The following is a description of a gene set: Human Gene Set: HP_NAIL_DYSTROPHY Onychodystrophy (nail dystrophy) refers to nail changes apart from changes of the color (nail dyschromia) and involves partial or complete disruption of the various keratinous layers of the nail plate. species: Homo sapiens Nail dystrophy, and this is the list of marker genes: RPA1, NHP2, RETREG1, DSP, TERT, KRT17, ATR, ATP2A2, GSN (gelsolin), GJB6, KRT6B, TYMS, BRAF, KIF15, TTC7A (tetratricopeptide repeat domain 7A), CD151, LSS, MPLKIP, WRAP53, PERP, KRT16, ATP6V1B2, LAMB3, COL14A1, KDF1, TNFRSF1B, FOXN1, ACD, MAP2K1, AARS1, IKBKG, LAMA3, PKP1, CTC1, GJA1, DKC1, MBTPS2, ZMPSTE24, KRT6A, PLEC, NLRP1, COX7B, GTF2H5, POLD3, DST, FGFR2, EVC2, PORCN (NCBI Gene Id 65017), LORICRIN, CARS1, KIF1A, AP1S3, ZBTB20, TARS1, PI4KA, EVC, CD28, HPGD, CTSC, HOXC13, ITGA6, NOP10, HLA-B, WNK1, KRAS (KRAS proto-oncogene, GTPase), TP53, RBCK1, FLNA, NECTIN1, AAGAB, KMT2D, ITGB4, SREBF1, MARS1, POMP, SMARCAD1, COL17A1, TERC, KRT85, PQBP1, JUP, NTRK1, ITGA3, NPM1, ERCC3, DCLRE1B, UBE2A, TP63, SCN9A (sodium voltage-gated channel alpha subunit 9), FOXP3, NOTCH1, CTLA4, RSPO1, IL36RN, KLHL24, TGM1, DNA2, KRT1, WNT10A, SMARCE1, SASH1, STING1, RTEL1, RUNX2, MAP2K2, STAT3, MTX2, WRN, GTF2E2, AIRE, MVK, NFKB2, TINF2, MMP1, GJB2, GRHL2, LMNA, NFKBIA, ATL1, PARN, KRT74 (NCBI Gene Id 121391), ANAPC1, FOCAD, CDSN, LAMC2, KRT86, PPP1R13L, DNAJC21, GABBR1, RECQL4, BANF1, ERCC2, KRT5, NAF1, TRPV3, COL7A1, USB1, KRT14, CSTA, DSG1, RNF113A, MAF, RAB7A, ABCA1